The following is a description of a gene set: Thick lower lip vermilion Human Gene Set: HP_THICK_LOWER_LIP_VERMILION studied in species Homo sapiens Increased thickness of the lower lip, leading to a prominent appearance of the lower lip. The height of the vermilion of the lower lip in the midline is more than 2 SD above the mean. Alternatively, an apparently increased height of the vermilion of the lower lip in the frontal view (subjective)., and this is the list of marker genes: FKBP6, LZTR1, ATP6V1B2, SMS, KRAS, SPRED2, STRADA, AP2M1, RPS6KA3, MLXIPL, VPS37D, FRMD4A, GLA, AMER1, ABCC9, AGA, KIF15, DPF2, NCF1, ARID1A, ECM1, SIN3A, SHOC2, RASA2, RRAS2, NAGA, ZBTB20, TAF4, LTBP1, COL11A1, SYNGAP1, PUS7, TMEM270, SOS2, AFF3, GTF2I, ANTXR1 (NCBI Gene Id 84168), SOS1, NANS, WDR26, PTH1R, EIF4H, KDM6A, FBXO11, BUD23, ZEB2, ATRX (ATRX chromatin remodeler), PSMB8, CA2, SMC5 (NCBI Gene Id 23137), ARID1B, SMARCA2, GJA5, GNAI1, SCN1A, DEAF1, FLNA, UGDH, HRAS, IDS, KCNN3, LIMK1, SMG9, GTF2IRD2, ARID2, NEXMIF, RBMX, EHMT1, BAZ1B, RRAS, ACER3, HECW2, RNF135, FTSJ1, RNU4-2, SOX11, HDAC4, CUL4B, SMARCB1, GJA8, SMARCC2, SLC6A1, FUCA1, SMARCE1, SLC2A1, PPP1CB, GLI2 (GLI family zinc finger 2), METTL27 (NCBI Gene Id 155368), HUWE1, RIT1, DYRK1A, TBC1D24, CDKL5, INSR, KIF11, RPS23, POU4F1, YY1 (YY1 transcription factor), GTF2IRD1 (GTF2I repeat domain containing 1), MED12, CDH11, CUL7, NEU1, CDT1, SMARCA4, ADNP, FBN1, CAMTA1, STX1A, TMEM53 (NCBI Gene Id 79639), CLIP2, SMARCD1, DNAJC30, RHOBTB2, MRAS, TASP1, PHGDH, KAT5, NRAS, TBL2, RFC2, SOX4, ELN, RAF1, EBF3, B9D1, RET, GNS, KMT2D, CBL, PTPN11, KMT2C, TMEM147 (NCBI Gene Id 84721), CHD2, SETD1B, LTBP3, PIGL